Given this list of marker genes Rbl1, Orc3 (origin recognition complex, subunit 3), Orc6, Ccnd1, Cdkn1c, Atm, Cdk1, Gadd45a, Cdkn1b, Mcm3, Rb1, Ccna1, Mcm7, Cdkn2a, Mcm5, Orc2 (NCBI Gene Id 98596), Cdk6, Mnat1, Mcm2, Cdkn2c, Pole, E2f2, Cdc45, E2f5 (NCBI Gene Id 99821), Ccnh, Cdkn1a, Prim1, Prim2, Tfdp1, Rpa3, Cdk2, Cdk7, Ccnd2, Rpa1, E2f4, Ccnd3, Cdc25a, Orc1, Myc, E2f6, Mdm2, Mcm6, Pole2, Pcna, Pola2, Pkmyt1, Ccne2, Orc5, Mcm4 (NCBI Gene Id 17217), Ccne1, E2f1, Rpa2 (NCBI Gene Id 99984), Ccng2, Cdkn2d, Trp53, Orc4, Cdkn2b, Tfdp2, Wee1, E2f3, here is a description of the gene set: species: Mus musculus Mouse Gene Set: WP_G1_TO_S_CELL_CYCLE_CONTROL G1 to S cell cycle control